The following is a description of a gene set: The chemical reactions and pathways resulting in the breakdown of pyrimidine nucleobases, 1,3-diazine, organic nitrogenous bases. species: Homo sapiens Human Gene Set: GOBP_PYRIMIDINE_NUCLEOBASE_CATABOLIC_PROCESS, and this is the list of marker genes: DPYSL2, ALDH6A1, DPYSL4, DPYSL5, DPYD, DPYS (NCBI Gene Id 1807), DPYSL3, CRMP1